The following is a description of a gene set: Any process that modulates the frequency, rate or extent of striated muscle cell differentiation. Mouse Gene Set: GOBP_REGULATION_OF_STRIATED_MUSCLE_CELL_DIFFERENTIATION studied in species Mus musculus, and this is the list of marker genes: Fzd7, Pak1, Tbx1, Shox2, Ybx1, Ezh2, Prox1, Hdac9, Mamstr, Hopx, Bcl2, Nr3c1, Mmp14, Ccn4, Ppara, Trim72, Rgs2, Ep300, Myf5, Csrp3, Bmp10, Tomm70a, Hdac4, Smad4, Pin1rt1, Ctdp1, Myf6, Zfp418, Mef2c, Mapk14, Bhlha15, Hamp2, Ddx39b, Fdps, Rbm38, Tgfb1, Myog, Msx1, Csf1r, Rbm10, Adrb1, Lmod3, Dkk1, Shh (sonic hedgehog), Gsk3b, Pin1, Wnt3a, Morf4l2, Parp2, Foxp1, Efnb2, Rbm24, Edn1 (endothelin 1), Piezo1 (piezo-type mechanosensitive ion channel component 1), Prkd1, Bmp4, Hdac5, Bmp2, Nkx2-5, Gsk3a, Mylk3, Actn3, Nln, Ankrd2, Fbxo22, Xbp1, Nrg1, Mesp1, Cyp26b1, G6pd2, G6pdx, Yy1, Akap6, Sox6, Rgs4, Rpl3l, Dmpk, Atp11a (NCBI Gene Id 75344), Cav3, Trim32, Notch1, Hdac3, Mtor, Trip10, Hamp, Sirt1 (sirtuin 1), Pi16, Frs2, Smyd1, Bhlhe41 (basic helix-loop-helix family, member e41), Ccnd2, Daxx, Plpp7, Bdnf, Slc25a4, Neu2, Igf1, Sik1, Tmem119, Myod1, Arrb2, Myocd, Dll1, Nek5, Kat2a, Maml1, Ccn3, Epc1